Given this list of marker genes Chrna2, Esyt2, Aldob, Nf1, Scarb2, Rpe65, Pitpnb, Abca1, Ilvbl, Pcyt1a, Ogdh, Serpina5, Apoa5, Apoa4, Tktl2, Tktl1 (NCBI Gene Id 97598), Ighm, Esyt1, Jchain, Pitpna, Pitpnm2, Apoa2, Gpr12, Gpr119, Chrna4, Hacl1, Dhtkd1, Pcyt1b (phosphate cytidylyltransferase 1, choline, beta isoform), Pitpnm1, Rasgrp1, Tkt, Pctp, Chmp3, Chrm3, Rs1, Pltp, Vdac1, Chmp2a, Chrnb2, Esyt3, Vdac2, here is a description of the gene set: studied in species Mus musculus Binding to a quaternary ammonium group, including glycine betaine, choline, carnitine and proline. A quaternary ammonium group is any compound that can be regarded as derived from ammonium hydroxide or an ammonium salt by replacement of all four hydrogen atoms of the NH4+ ion by organic groups. Mouse Gene Set: GOMF_QUATERNARY_AMMONIUM_GROUP_BINDING